Given this list of marker genes STX19, CHMP7, RPH3A, CLSTN3, VPS33B, RUFY1, VAV3, RAB7B, IRAG2, MSTO1, SYT5, RAB3A, CHMP1A, RPH3AL, STXBP6, SYT2, YIPF5, ATL2 (NCBI Gene Id 64225), RAB20, SYT8, GOSR2, PID1, UVRAG, USO1, NME3, CHMP2A, AFG3L2, STX1A, PIP4K2A, LDAH, STX10, MFN1, SAMD9, MIGA2, CIDEA, GDAP1 (NCBI Gene Id 54332), CHMP4B, MFN2, RCC1L, TRARG1, MCL1, VAMP8, PARL, CHMP4A, CHMP1B, VAMP2, SYT1, PRKN, SNAP29, SEPTIN8, ARL8B, VPS41, BNIP1, CIDEB, OMA1 (NCBI Gene Id 115209), RAB4B, PIP4K2B, PLA2G5, CPLANE2, PLEKHM1, VPS8, RAB39A, RAB34, BAX, STX6, CHMP6, OPA1, LRRK2, SYT7, SNCA, CHCHD3, VAMP3, TOM1, STX4, SPG11, STX1B, DIAPH3, YIPF4, RAB2A (RAB2A, member RAS oncogene family), VPS16, ADCK1, MIEF2, USP30, RAB8A, CORO1A, CPLX3, CHMP4C, SOX30, SNAP25, ERC2, C9orf72, YIPF7, EEA1, STX8, CAV2, TGFBRAP1, TRABD, STXBP1, FUNDC1, BNIP3 (BCL2 interacting protein 3), PLD6, VPS4A, GOSR1, VPS18, SYT3, TMEM175, SNAP47 (NCBI Gene Id 116841), CYP26C1, TSNARE1, CPLX2, BAK1, DOC2B, VAMP1, SPHK1, ANXA2, VIPAS39, BCL2A1, SYT4, STX5, ANKFY1, ZNRF2, ATL3, RUBCNL, VCPIP1, MIGA1, PIKFYVE, SNAPIN, STX7, CDK1, GRIK5, KIAA0319L, RAB7A, SYT11, ZNRF1, VPS11, HUWE1, VTI1B, MUL1, VAMP7, ANKRD27, STOML2, ANXA1, SYT13, TBC1D4 (NCBI Gene Id 9882), STX2, STX12, PNPLA2, CIDEC, MTCH2, ATP13A2, PRRT2, SLAMF1, VAT1, CHMP2B, TFRC, STX11, YME1L1, ATL1, CLTRN, RUFY4, CHMP3, ZDHHC6, STX16, BET1, CPLX1, VAMP4, RAB14, VTI1A, SNAP23, CLN3, STX3, HID1, SYT9, C2CD5, THG1L, VPS33A, DOC2A, MIEF1, CPLX4, CHMP5, VPS39, STX17, PCDHGA3, NKD2, here is a description of the gene set: The creation of a single organelle from two or more organelles. Human Gene Set: GOBP_ORGANELLE_FUSION studied in species Homo sapiens